The following is a description of a gene set: A toll-like receptor signaling pathway not relying on the MyD88 adaptor molecule. Toll-like receptors directly bind pattern motifs from a variety of microbial sources to initiate innate an immune response. studied in species Homo sapiens Human Gene Set: GOBP_MYD88_INDEPENDENT_TOLL_LIKE_RECEPTOR_SIGNALING_PATHWAY, and this is the list of marker genes: MAP3K7, TNIP3, IRF3, TICAM2, TRAF3, TRAF6, TLR4, PRKCE, TLR6, TICAM1, CD274, IKBKB, SARM1, CD300LF, IRF7, RAB11FIP2